Given this list of marker genes RFPL3, TRIM6, TRIM15, GGT3P, KCTD10, HERC2P3, RNF43, PELI2, UBR1, RNF13, FBXO2, RNF138, TRIB1, EGR2, MYCBP2, MIB2, BIRC2 (baculoviral IAP repeat containing 2), CUL4A, UBE2E3, TRIM48, RNF216, RNF34, MED10, BMI1, TRIM64, RNF26, NT5C2, MGRN1, FBXO10, UBE2J1, RNF133 (ring finger protein 133), RNF166, NCCRP1, MDM2, NOSIP, FBXO5, ENTREP1, UBE2M, TRIM43, CBLC, RNF19A, RNF168, RABGEF1, TRIB2, HERC4, PEX2, FBXL21P, NEDD4, TRIM49, SH3RF1, TRIM22, CUL9, BAG5, TRAF5, RANBP2, FBXW2, TGM3, HERC5, RNF40, FBXO44, TRIM63, MARCHF11, ANKIB1, AKTIP, MED12, RNF217, SMURF1, RING1, RFWD3, HECTD3, RNF170, WDSUB1, UBR5, ANAPC4, TRIM49D1, ATG3, NEDD4L, DTX1, COP1, RAD18, LNX2 (ligand of numb-protein X 2), LMO7, TRIM14, RNF11, HERC2, RPGR, AMFR, CUL2, PIAS1, MED17, RNF228, ZNRF2, RNF146, RNF135, UBE2B, BRCA1, MARCHF5, WWP1, PIN1, UBA3, RNF8, TRIM21, TRIM35, TRIM54, F13A1, TGM7, ASB2, MUL1, UHRF2, NEURL1, TRIM49D2, RNF39, TRIM31, UBOX5, CBX8, RBBP6, TRIM28, TRIM69, CDKN1B, UBE2F, RNF215, XIAP, RNF183, TRIM43B, FBXL22, ATE1, TMEM129, RNF212B, TRIM55, TTC3, LRSAM1, IRF2BPL, GGT7, RPL37, TRIM40, RNF6, MARCHF1, RNF103, TRIM3, UBE2W, RNF111, RNF220, TRAF3IP2, RLIM, TGM6, VPS18, TRIM64B, PIAS4, RNF122, TRIB3, TRIM77, WDR24, TRAF2, CDC42, TNFAIP3, RNF44, RNF185, RNF212, BIRC7, SHARPIN, RNF31, ATG12, RC3H2, NHLRC1, MED8 (NCBI Gene Id 115853), BTRC, TGM5, TRIM11, ZNF738, TRIM33, KCMF1 (potassium channel modulatory factor 1), SPRY2, TRIM24, ASB4, UBE2R2, SH3RF3, TRIM25, KLHL20, UHRF1, TRAF6, MED7, TRIM68, MKRN1 (makorin ring finger protein 1), TRIP12, RNF128, UBA7, MED6, CUL5, UBE2D3, FBXO3, RNF167, UBR7, OTUB1, STUB1, TRIM62 (tripartite motif containing 62), UBE2H, PCGF3, MED27, RNF150, MDM4, TRIML2, FBXL6, MSL2, CHFR, RNF125, HTRA2, NEURL3, UBE3C, FBXO6, EPB42, RPL11 (NCBI Gene Id 6135), FBXO9, SIAH2, TRAIP, TGM4, MED11 (mediator complex subunit 11), RNF225 (NCBI Gene Id 649689), MEX3C, ZMIZ2, TRIM74, ASB12, NHLRC3, ARIH1, TRIM58, RNF5, PPP1R11, RNF14, RNF139, MARCHF8, KCTD13, RPL5, TGM1, ARIH2, DCST1, KIAA1586 (NCBI Gene Id 57691), RNF213, TRIM17, RNF223, UBE4A, FBXO7, MARCHF4, RNF2, BSPRY, PRPF19, SH3RF2, CBLL1, MARCHF2, RNF187, HERC6, KLHL9, HERC3, ZNRF3, DTL, NEURL1B, HLTF, TAF1, TRIM5, UBE2L3, RNF130, RNFT1, OBI1, UBE2L6, PEX10, CDC20B, FBXO17, SYVN1 (synoviolin 1), FBXL5, RNF38, UBE3D, RBX1, PARK7, MKRN3, TRIM10, TRIM71, VHL, RNF121, UBE2A, ZSWIM2, UBE2K, UBE2I (NCBI Gene Id 7329), UBE2Z, C10orf90, UFL1, WWP2 (NCBI Gene Id 116013), RMND5B, UBR3, LTN1, WSB1, RNF4, LNX1, FZR1, ZNRF1, UBE2U, UBE2Q1, RPS15, RSPRY1, TRIM13, ATG10 (NCBI Gene Id 83734), RNF7, RNF180, PIAS2, SIAH1, IRF2BP1, UBE2E1, RNF169, ASB1, TRIM51 (NCBI Gene Id 92637), MED1, FBXL3, FBXO21, MED30, FBXO4, ATG16L1, MAGEL2, TRIM41, RNF115, KLHL21, UBE4B, LIMK1, CDC23, TRIM23, ZNF451, TRIM34, UBE2L5, RFPL1, CDC34, BARD1, MARCHF9, UBE2G1, UBR2, CDC20, DTX3L, TRIM49B (tripartite motif containing 49B), RNF114, HECTD2, TRIM60, RNF186, CCNB1IP1, FBXO11, PRKN, MKRN2, UBE2C, MYLIP, FBXO30, RNF112, RNF145, TRIM45, UBE2NL, RNF141, TRIM75, RNF208, DZIP3, DTX2, KLHL42, GGT5, DTX4, G2E3, PCGF5, RPL23, TRIM44, RNF152, TRIM52, GGT6, TOPORS, TRIM51G, SIAH3, RNF19B, BCOR, SMURF2, TRIM72, CBX4, CBLL2, TRAF3, ANAPC11, NEURL2, LONRF2, UBR4, ZNRF4, CCAR1, HECW1, UBE3A, RFPL4B, BIRC8, RAG1, PML, PIAS3, TRAF7, RNF113A, RBCK1, TRIM65, ARK2C, TRIM4, RFPL4A (ret finger protein like 4A), PJA1, UBE2N, TRIM47, ITCH, UBE2D2, TNFAIP1, ARHGAP5-AS1, UBE2V1, SUMO2, PTEN, RFPL4AL1, HECTD1, BIRC6, TRIM49C, TRIM27, RPS7, TRIM26, ARK2N, FBXW7, RNF41, SHPRH, RNF182, TRIM38, BFAR, UBE3B, RPS20, CUL3, PPIL2, GID4, UBE2S, TRIM39, GGT1, BIRC3, FBXO24, TRIM2, GLMN, FBXL14, MARCHF3, ZMIZ1, QPCT, TRIML1, FBXO22, RNF227, UBE2Q2, RNFT2, MAEA, PELI3, UBE2D4, UBE2D1, RNF214, RNF20, UBE2QL1, RNF149, QPCTL, CBLB, MARCHF6, RNF175, ZBED1 (zinc finger BED-type containing 1), RC3H1, UBE2O, NEURL4, KLHL13, HERC1 (HECT and RLD domain containing E3 ubiquitin protein ligase family member 1), TRIM56, VPS11, MED21, TRIM37, NFX1, CBL, MEFV, MED31, RNF181, RNF144A, DTX3, PJA2, TRIM73, ZNF598, RNF126, RNF123, HDAC7, MALT1, RMND5A, UBL4A, UFC1, HECW2, TRIM7, RFFL, RNF148, TRIM8, ATG5, HACE1, PEX12, GCN1, RNF157, UBE2E2, RCHY1, RNF144B, FANCL, HECTD4, CNOT4, UBE2G2, TRIM36, ZFP91, TRIM59, TRIM61, CDKN2A, RNF25, FBXO27, TGM2, RFPL2, HUWE1, TRIM9, TRIM64C, FBXO25, MIB1, AREL1, FBXO40, NSMCE2, UBE2J2, RNF10, NSMCE1, PDZRN3, BRAP, HDAC4, TRIM42, TRIM50, TRIM32, DDB2, MARCHF7, UBE2T, PELI1, here is a description of the gene set: species: Homo sapiens Catalysis of the transfer of an amino-acyl group from one compound (donor) to another (acceptor). Human Gene Set: GOMF_AMINOACYLTRANSFERASE_ACTIVITY